Given this list of marker genes ACTA2, TBX1, SON, NKX2-6, PLXND1, here is a description of the gene set: An abnormality of the common carotid arteries, which provide the arterial supply to the head and neck and give rise to the internal carotid artery and the external carotid artery. species: Homo sapiens Abnormal common carotid artery morphology Human Gene Set: HP_ABNORMAL_COMMON_CAROTID_ARTERY_MORPHOLOGY